The following is a description of a gene set: Mouse Gene Set: GOBP_CHAPERONE_COFACTOR_DEPENDENT_PROTEIN_REFOLDING The process of assisting in the correct posttranslational noncovalent assembly of proteins, which is dependent on additional protein cofactors. This process occurs over one or several cycles of nucleotide hydrolysis-dependent binding and release. species: Mus musculus, and this is the list of marker genes: Hspa13, Dnajc7 (NCBI Gene Id 67633), Hspe1-rs1, Dnajb5, Hspa9, H2-DMb2, Tor2a (torsin family 2, member A), Ptges3-ps, H2-DMa, Sdf2l1, St13, Ero1a, Bag1, Hspe1, Hspa8, Hspa14, Hspa1b (heat shock protein 1B), Dnajb1, Dnajb4 (NCBI Gene Id 76019), Sdf2, Hsph1, Hspa5, Dnajb12, Hspa1l, Hspa2, Cd74, Ptges3, Hspa1a, Tor1b (torsin family 1, member B), Dnajc18, H2-DMb1, Dnajb14, Dnajb13, Tor1a